The following is a description of a gene set: Macrocephaly studied in species Homo sapiens Human Gene Set: HP_MACROCEPHALY Occipitofrontal (head) circumference greater than 97th centile compared to appropriate, age matched, sex-matched normal standards. Alternatively, a apparently increased size of the cranium., and this is the list of marker genes: HECW2, NSD1, PEX3, MPDZ, FOXP2, SHOC2, RXYLT1, TRAF7, MACROH2A1, DLK1, FLI1, OTUD5, MGAT2, CAMK2A, HELLS, GRB10, ZBTB7A, SIX3, MYH8, SHPK, PPP1CB, TBX15, NF1, PEX1, CNTNAP2, KCNH1, LFNG, DMPK, HECTD4, POMT1, PTHLH, RERE, ZBTB42, MAX, CCDC28B, LARGE1, SMARCB1, FAM111A, MTM1, ABCC9, EZH2, TBL1X, SLC16A2, SNX14, SPTBN1, SETD2, POMK, RRAGC, APC2, HSD17B4, KCNJ1, PKDCC, ITCH, BRAF, DNMT3B, GLI2, DEPDC5, H3-3B, IFT74, AQP4, GCDH, LMNA, TBX6, RAB34, PTCH2, MAB21L2, KDM1A, EDN1, GRIA3, MOCS2, SPIN4, POLE, NAA60, TET3, LAMA5, JARID2, NODAL, SOX9, GAS1, DVL3, L1CAM, FOXP1, KMT2E, OBSL1, SHANK3, SMC1A (structural maintenance of chromosomes 1A), SLC39A14, SH2B1 (SH2B adaptor protein 1), GNS, KIF7, PIK3R2, ETFA, CLCN7, PEX14, ARL6, PIBF1, MTOR, FZD2, POC1A, SUZ12, POMT2, SEC23B, CTNNA2, GAD1, USF3, GJA1, LRP4, TBCK, BICRA, RUNX2 (RUNX family transcription factor 2), GUSB, KMT5B, CSGALNACT1, LAMB1, HEPACAM, DISP1, MITF, TBC1D2B, TUBB2B, DOCK6, ETFB, EXT2, POR, SPRED1, TMEM216, AKT3, B3GLCT, KDM5C, SLC2A10, MED12, USP7, MAN2B1, ZBTB20, POU4F1, SDHD, NRAS, RAB39B, CAMTA1, SON, SATB2, BIN1, INPP5E, DPH1, BMP2, USP9X, FMR1, PLAG1, POMGNT2, SYN1, GLI3, FIBP, CRELD1, FGD1, GNAQ, DVL1, ODC1, SPTSSA, SMO, STIL, HDAC6, AXIN1, CHD3, UBE2A, BLTP1, DLL1, NEU1, TGIF1, STX4, ACADVL, ERMARD (ER membrane associated RNA degradation), L2HGDH, KRAS, HRAS, AGGF1, NALCN, PIGA, POLR1A, APC, FGFR2, CHD4, PLG, CC2D2A, PTDSS1, DHCR24, HEXB, ALKBH8, RYR1, PPP2CA, TFE3, PITX1, ADGRL1, FGF8, TAOK1, PEX19, GPRC5B, PTEN, MEG3, ZDHHC9, OPHN1, SLC12A2, NONO, DAG1 (NCBI Gene Id 1605), XYLT1, PTCH1 (NCBI Gene Id 8015), AKT1, KANSL1, ALDH1A2, MESP2, SDHB, B3GALNT2, LRP2, GNE, PLCH1, ZBTB24, PHF6, ANTXR2, PLEC, AP1S2, RTL1, CRPPA, STRADA, SRRM2, TONSL, PIGN, ZNF469, KCNC2, NFIB, ANKRD17, PTPN11, FBN1, HDAC4, OFD1, NLRP3, RPGRIP1L, MECP2, CCDC22 (coiled-coil domain containing 22), DICER1, TMCO1, CAMK2G, SERPINH1, POP1, MEGF8, ANKH, IHH, RAC1, ETFDH, GAN, TRIP11 (thyroid hormone receptor interactor 11), CLCN4, UBE3A, HOXD13, NKX3-2, CWC27, PEX10, GABBR2, CDON, WNT5A, B4GALT7, H1-4, MLC1, TCF20, ACAN, FIG4, DPYSL5, LBR, WDR35, SRPK3, TRIM37, ALG13, ZMPSTE24, SLC29A3, BGN, SMPD1, ZIC2, IGBP1, ERF, PPP2R5D, MYT1L, SUFU, HUWE1, FBXW7, MSX2, MAN1B1, NDUFAF3, RNF135, VPS35L, FH (NCBI Gene Id 83748), SLC35D1, RIT1, MTMR14, DLL3, BBS1, B4GAT1, SIM1, MYMK, FGFR1, FOCAD, DYNC2H1, MRAS, HMGA2, PEX6, SLC25A1, SOS1, IL6ST, MAN2C1, RIN2, DYNC2I1, AFF2, ZFX (NCBI Gene Id 7543), CDC42BPB, PEX11B, PLCB4, SDHC, H19, CDCA7, CSF1R, PEX2, WASHC5, SLC26A2, EML1, GNB1, CDH2, FAM149B1, TMEM67, ACER3, SRCAP, RFX7, DEAF1, SP7, ACADM (acyl-CoA dehydrogenase medium chain), ASPA, PDSS1, RIPPLY2, FBXO11, CHD8, BRWD3, PEX16 (peroxisomal biogenesis factor 16), IFT43, BMPR1A, ANK3, TBC1D7, LZTR1, FKTN, HES7, ASXL2, CCNK, COL2A1, CLCN3, SLC2A1, MOCS1 (molybdenum cofactor synthesis 1), CUL4B, SUMF1, EIF2B1, CHRNA7, IFT80, NFIA, FGFR3, TUBA1A, TMEM94, RNF125, GPC3, PPP1R12A, TUBB3, ZSWIM6 (zinc finger SWIM-type containing 6), YME1L1, THRA, SMAD4, TMEM53, STAG2, HERC1, PAK1, GFAP, TCIRG1, SETD1A, IGF2, FOXH1, GNAI3, KLLN, KCNJ8, DNM2, MAP2K2 (mitogen-activated protein kinase kinase 2), COL4A1, D2HGDH, SPINT2, MAP2K1, IDS, ROBO3, NOTCH2, RAB23, CHD1, FKRP (fukutin related protein), POMGNT1, PCGF2, PIK3CA, SHH, SNX10 (NCBI Gene Id 29887), CRIPTO (cripto, EGF-CFC family member, NCBI Gene Id 6997), B4GALT1, BICD2, CACNA1E, SIX2, DYNC2I2, NFIX, DOCK3, AHDC1, DPYD, FAR1, UHRF1, CCND2, IDH1, NDUFV1, PDGFRB, EED, PEX26, TNFRSF11B, PHF21A, PEX13, KPTN, PIGT, DNMT3A, ADK, DIS3L2, TNRC6B, ASH1L (ASH1 like histone lysine methyltransferase), PEX5, NXN, H3-3A, IFT81 (NCBI Gene Id 83713), AMER1, IDUA (alpha-L-iduronidase), PEX12, MYF6, TNFSF11, UPF3B, CEP120, RAF1, DPH2, TNFRSF11A, INPPL1, GPC4, GNB2, ROR2, TRIO (trio Rho guanine nucleotide exchange factor), STT3A, EIF4A2, ARSB, SEC24D, NDUFS4, SEC23A (NCBI Gene Id 353367), SOST, LRP5, POLR3A, CDKN1C